Given this list of marker genes Rb1, Ccne1, Ccne2, here is a description of the gene set: This event has been computationally inferred from an event that has been demonstrated in another species.<p>The inference is based on the homology mapping from PANTHER. Briefly, reactions for which all involved PhysicalEntities (in input, output and catalyst) have a mapped orthologue/paralogue (for complexes at least 75% of components must have a mapping) are inferred to the other species. part of: Cyclin E associated events during G1/S transition  electronically inferred by orthology from the curated human pathway species: Mus musculus Reactome Pathway: Phosphorylation of proteins involved in G1/S transition by active Cyclin E:Cdk2 complexes